The following is a description of a gene set: Human Gene Set: MODULE_92 Secreted signaling molecules. species: Homo sapiens, and this is the list of marker genes: GRAP2, EFNA1, NCAM1, CARTPT, CEACAM6, MDK, IL6, TNFSF9, TFAP2C, WNT5A, SLC6A4, CCL3, XCL1, ARL4D, IL11, STC1, BST2, ZYX, CCL11, CXCL12, ACSL1, DLGAP1, FGFBP1, ADRA1D, MERTK, CXCL9, NGF, STC2, IL15, SNAP25, AKR1C2, BAIAP3, WNT3A, NAMPT (NCBI Gene Id 10135), EFNB2, CCR1, PTGIR, CXCL10, CCL15, TFF1, AGT, NOS1, NMU, S100A9, CTSE, CHRNB1, C1QA, ADRA2B, CXCL6, FABP1, CCL23 (NCBI Gene Id 6368), IL18, FGF9, CCL18 (NCBI Gene Id 6362), TSHB, GJA1, TNFSF10, FAT1, GRN, LALBA, ADORA1, IL1B, CCL17, CCL8, STX1A, INHBA, ENPEP, PRSS2, CSF3, SCTR, TFF2, EDN3, CCL2, SST, PDGFA, CHRNE, FURIN, PGC, EREG, CGA, TGFA, PCSK1, VIP, GRB10, ADORA2A, CXCL5, CCL4, AR, TFF3, CGB3, EFNB3, OSM, EDN2, CRB1 (crumbs cell polarity complex component 1), S100A6, NEO1, SNPH, IL1A, CCL13, CXCL14, LHB, AREG, PENK, CXCL8, ASIP, ADM, CCR5, CX3CL1, FGF7, CCL22, ISG15, VIPR1, NRG2, WNT4, FGF11, FABP2, CCL7, STATH, BMP2, CXCL13, IL3, SCG2, TRH, FASLG, TEK, PPY, LTBP2, NQO1, IL9, LIF, FGF4, CALCA, TGFB3, EDN1, GJB2, NPY, PCDH1, CHRNB4, SEMA3B, GLUL, NRP1, CCN5, AMY2B, LTB, CCL21, GJB1, CCL20, INSL4, LILRB2